Given this list of marker genes Sox11, Tnks, Hipk1, Dzip1, Smad3, Trim21, Ifi208, Pinx1, Cthrc1, Gas8, Plk1, Mitd1, Ddrgk1 (NCBI Gene Id 98926), Smad2, Ebf2, Ifng, Zfpm1, Epb41l5, Ifi203, Ager, Cdt1, Tns3, Ifi203-ps, Zfp618, Nme1 (NCBI Gene Id 18102), Hand2, Ephb6, Nog, Eif3e, S100a10, Myocd (NCBI Gene Id 214384), Zfp90, Smim6, Styx, Cdkn1a, Wfikkn2, Atp2a3, Carm1, Msx2, App, Cdon, Ripk2, Dnaaf11, Dab2, Med25, Ddx11, Smarca4, Prkn, Bmp2, Nfatc4, Cdc42, Tiam1, Akt1, Trim28, Bdnf, Itga4, Bax, Bmncr, Tert, Rgma, Grem2, B2m, Sirt2, Styx-ps, Plscr1, Pou4f1, Pcsk9, Calm1, Ngf, Pin1rt1, Rara, Igf1, Mmp9 (NCBI Gene Id 99431), Traf3ip1, Taf10, Id1, Nek2, Wnt5a, Zfp462, Src, Tmem132a, Rock1, Itgb1bp1, Tunar, Nmd3, Zc4h2, Id2, Mapre1, Lif (NCBI Gene Id 16878), Runx1t1, Arhgef7, Plcl1, Trib3, Pex14, Sympk, Tnfsf11, Txn1, Cpne1, Ifi213, Ins2, Spon1, Gsk3b, Pln, Psen1, Ccm2l (NCBI Gene Id 228788), Stmn1, Shh, Pcbd1, Mcrip1, Sting1, Tgfb1, Ifi207, Angpt1, Pabpn1l, Hey2, Bambi, Mapk8 (mitogen-activated protein kinase 8), Rb1, Sln, Pex19, Smo (smoothened, frizzled class receptor), Mad2l2, Gm2044 (predicted gene 2044), Crtac1, Traf3ip3, Epb41, Lrrk2, Ifi206 (interferon activated gene 206), Hdac4, Ripor2, Larp7, Eif4g1, Gata1, Ctbp2, Camk1, Ip6k2, Hmgb1, Nvl, Aktip, Btaf1, Cblb, Kdm4d, Rpl11, Irf4 (interferon regulatory factor 4), Hip1r, Fbxw7, Ccpg1 (cell cycle progression 1), Ptprf, Parp9, Golga2, Aplp2, Bmp4, Tex14, Cdkn2a, Dhrs7b, Dph3, Dtx3l, Eif2ak3, Gpsm1, Blk, Jun, E2f1, Lhx2, Cln5, Slpi, Epha4, Il10, Met, Pax6, Mfng, Cycs, Cd2ap, Bag2, Abl2, Gtpbp4, Usp9x, Pim2, Lfng, Abl1, Niban2, Ncbp1, Dact1, Ran, Hcfc2, Ski, Dot1l, Dnajb2, Tdg, Ubash3b, Tle5, Hjurp, Egf, Gnl3l, Cyld, Zbtb7a, Traf6, Lrp1, Rack1, Hand1, Atr, Mrln, Fktn, Jak2, Ifi214, Hmga2, Mark3, Phlda2, Isl1, Ifit2, Rfng, Ide, Fbh1, Twist1, Pygo2, Kdm1a, Hdac5, Errfi1, Adipoq, Ctnnbip1, H1f0, H2bc1, Mapre3, Ybx2, Edf1, Nsd1, Tgfb2, Ticam1, Foxc1, Smad4, Sumo3, Arhgap28, Fam220a, Trim6, Tmc8, Dscam, Cdk5, Mapk3, Ralb, Hipk3, Plaur, Ercc2, Add1, Xirp1, Ep300, Anxa2, Psme3ip1, Plcl2, Ifi209, Mndal, Ttc36 (NCBI Gene Id 192653), Aurkb, Rnf220 (NCBI Gene Id 70613), Habp4, Psen2, Sp100, Pdgfb, Spta1, Vtn, Gmnn, Eno1, Nes, Mepce, Usp33 (ubiquitin specific peptidase 33), Brd4, Pitx2, Cp, Lrp12, Snapin, Tcf7l2, Atp2a2, Dazap2 (NCBI Gene Id 23994), Gzma, Dtnbp1, Ripor1, Lox, Large1, Pax7, Lrpap1, Hopx, Zbtb7c, Lef1, Gata3, Mdga1, Ilrun, Park7 (NCBI Gene Id 57320), Ttbk1, Smarcd3, Ufl1 (NCBI Gene Id 67490), Plxnd1, Ppp3ca, Ckmt1, Tfap4, Myod1, Wfikkn1, Pin1, Gtf2f1, Frmd7, Septin7, Adam15, Rapgef2, Dkk1, Pou4f2, Rsf1, Senp2, Agrn, Myc, Twist2, Spag8 (sperm associated antigen 8), 1810037I17Rik, Tfip11, Aurka, Tgfbr1, Wapl, Neurod1, Flot1, Hmgb2, Blm, Efhb, Nphp3, Ldlrap1, Ttbk2, Cldn5 (NCBI Gene Id 21920), Mdfi (NCBI Gene Id 17240), Stub1, Lamtor5, Add2, Hipk2, Hfe, Nfib, Krit1, Sumo1, Hes1, Zmpste24, Msx1, Eif3d, Mir744, Gemin2, Tmbim6, Ppdpf, Ldoc1 (regulator of NFKB signaling), here is a description of the gene set: Any process that modulates the frequency, rate or extent of binding, the selective interaction of a molecule with one or more specific sites on another molecule. Mouse Gene Set: GOBP_REGULATION_OF_BINDING species: Mus musculus